Given this list of marker genes CLPB, GATM, MAPKBP1 (mitogen-activated protein kinase binding protein 1), NUP54, DENND2C, PTPRS, RAB3IL1, LBR, SSRP1, IFT122, EXOSC2, APBB2 (NCBI Gene Id 323), ERMAP, LARP7, GFI1B, UROD, PPIE, KLHDC8B, APOE, RPS27L, RAPGEFL1, GRK6, MKI67, SEPTIN14, COX6A1, CDC6, CPOX, HFM1, DUT, PALLD, PRDX4, DOCK7, AQP1, ZG16, SERINC5, MCM10, TREML2, EPN1, HYAL3, TSGA10 (testis specific 10), ASF1B, CNOT9, SNRPD3 (NCBI Gene Id 6634), ZRANB3, ARHGAP33 (NCBI Gene Id 93092), EMC6, SLC22A23, MPO, AGAP1 (NCBI Gene Id 22851), PCOLCE2, MAP3K1, EXOSC7, NDUFB9, TMPRSS3, GPM6B, PRDX2, PCYT1B, PES1, HDGF, PAQR9, SEC14L2, CRYGN, UHRF1, MESD, ELANE, CENPV, RIT1, BUB3 (BUB3 mitotic checkpoint protein), PBK, GSPT2, PPP1R12B, PARP1, ABCD3, RFC5, AKT1S1, RPS6KC1, STARD10, ZDHHC14 (NCBI Gene Id 79683), DNAJC6, CENPS, SEPTIN4, TUBGCP2, RRP8, AGPAT3, PKHD1L1, ARPC5L, ZFPM1, ATP1B2, HYI, QSOX1, TSSC4, PPA1, CARHSP1, TAB1, BTBD2, GDF3, RPS4Y2, TOMM5, ACACA, PRTN3, SLC40A1, SIRT6, TARBP1, ADCY6, SYMPK, TRIM34, NEK2, NXPE3, MCM3AP, NECTIN4, CBX1, GCLM, HECTD1, SERPINA7, PPP6R2, CHST3, DFFA, TGM1 (transglutaminase 1), SPATA24, PMF1 (NCBI Gene Id 94958), ABCB10, ALAS2, NMRAL1, CFP, CD109 (NCBI Gene Id 135228), CS, THOC3, FERMT1, IL9R, CLN8, IGSF3, PPP5C, IQCE, FADS2, TEX101, KLF1, RPIA, OCEL1 (NCBI Gene Id 79629), TMEM147, RNF122, NR1I3, EDC3, WFDC9, AEN, H1-1, KIF14, TMED3, CC2D1B, PAXX, HEMGN, MRPL34, SNRPC, GLRX5, CCDC77, CSNK1A1, PLEKHA2, UQCRQ, TAF5L, NIFK, PMM1, GATA1, SDHAF3, GAPVD1, RBMX2, MSRA, ACO1, RPL23 (NCBI Gene Id 9349), UBTF, PIEZO1, here is a description of the gene set: Genes down-regulated in CD4 T conv: control versus over-expression of LEF1 and FOXP3. species: Homo sapiens The transcription factor FoxP3 partakes dominantly in the specification and function of FoxP3+ CD4+ T regulatory cells (Tregs), but is neither strictly necessary nor sufficient to determine the characteristic Treg transcriptional signature. Computational network inference and experimental testing assessed the contribution of several other transcription factors (TFs). Enforced expression of Helios or Xbp1 elicited specific signatures, but Eos, Irf4, Satb1, Lef1 and Gata1 elicited exactly the same outcome, synergizing with FoxP3 to activate most of the Treg signature, including key TFs, and enhancing FoxP3 occupancy at its genomic targets. Conversely, the Treg signature was robust to inactivation of any single cofactor. A redundant genetic switch thus locks-in the Treg phenotype, a model which accounts for several aspects of Treg physiology, differentiation and stability. from publication Fu W, Ergun A, Lu T, Hill JA, Haxhinasto S, Fassett MS, Gazit R, Adoro S, Glimcher L, Chan S, Kastner P, Rossi D, Collins JJ, Mathis D, Benoist C (PMID 22961053) Human Gene Set: GSE40274_CTRL_VS_FOXP3_AND_LEF1_TRANSDUCED_ACTIVATED_CD4_TCELL_DN